Given this list of marker genes Taf5l, Ppip5k2, Dcaf10, Atg13, Elmod1, Tmem150b, Tm7sf3, Vwa1, Anks1, Pla2g12a, Cited2, Zfpm2, Prkag2, Dnmt3a, Fez2, Nfasc, Btrc, Birc3, Rnf38, Syncrip, Mbnl1, Fam76a, Ngef, Hook3, Trim32, Tex13b, Ppm1l, Desi1 (NCBI Gene Id 28075), Cpeb3, Paip1, Srrm4, Etl4, Ghsr, Kmt2d, Il21r, Grm7, Mrpl58, Csnk1g3, Tpp1, Pygo2, Arl5a, Negr1, Rasl12, Aif1l, Pyurf, Agmat, Capn8, Lpar6, Pcdh19, Nfib, Ice1, D830030K20Rik, Zhx1, Unc13c, Osbpl6, here is a description of the gene set: from publication Chen Y, Wang X (PMID 31504780) Mouse Gene Set: MIR_7044_3P Genes predicted to be targets of miRBase v22 microRNA mmu_miR_7044_3p in miRDB v6.0 with MirTarget v4 prediction scores > 80 (high confidence targets). studied in species Mus musculus